The following is a description of a gene set: Any process that activates or increases the frequency, rate or extent of apoptotic cell clearance. studied in species Mus musculus Mouse Gene Set: GOBP_POSITIVE_REGULATION_OF_APOPTOTIC_CELL_CLEARANCE, and this is the list of marker genes: Cd300lf, Ccl2, C2, Abca7, Trem2, C3